The following is a description of a gene set: Genes predicted to be targets of miRBase v22 microRNA mmu_miR_5622_5p in miRDB v6.0 with MirTarget v4 prediction scores > 80 (high confidence targets). Mouse Gene Set: MIR_5622_5P from publication Chen Y, Wang X (PMID 31504780) studied in species Mus musculus, and this is the list of marker genes: Map7d2 (NCBI Gene Id 78283), Nrf1, Txlng, Zfp758, Mbnl3, Lrrc39, Lrrc4c, Atp6v1a, Selenoi, Trit1, Nmb (NCBI Gene Id 68039, neuromedin B), Stk38, Kcnj5, Rbm27, Spin1, Phka1, Dr1, Scimp, Gria2, Fank1, Syt9, Lgsn, Slitrk4, Adamts5, Ttpal, Bdh1, Rbm34 (RNA binding motif protein 34), Csf1, Ankrd22, Cilp, Rcan2, Stag2, Tlcd4, Ebf3, Ugcg, Kpna6, Ipo8, Zyg11a, Zfp788, Ptpn9, Mef2a, Nox4, Usp45, Thsd7a, Pianp, Rnf138, Palld, Ubr3, Dock9, Rasl2-9, Ttc7b, Zfp971, Lrrtm3, Usf3, Ctnna1, Endod1, Clns1a, Atxn3 (ataxin 3), Cldnd1, Foxj2, Map1b, Fzd3, Dynap, Myb, Lrfn5, Cxadr, Ubxn7, Armc1, Arl6ip1, Thap12, Mospd2, Ctnnd1 (NCBI Gene Id 99192), Shisa3, Dnajb6, Cecr2